Given this list of marker genes Uba52rt, Ubc (ubiquitin C), Uba52, Rps27a, Ubb, here is a description of the gene set: Mouse Gene Set: REACTOME_ER_QUALITY_CONTROL_COMPARTMENT_ERQC ER Quality Control Compartment (ERQC) studied in species Mus musculus